Given this list of marker genes MAPK10, RPS6KA5, MAPK3, ELK1, MAPK8, ATF2, CREB1, PPP2R1B, MEF2A, RPS6KA3, MAPKAPK2, MEF2C, PPP2R5D, VRK3, RPS6KA2, JUN, PPP2CB (NCBI Gene Id 5516), FOS, DUSP3, RPS6KA1, ATF1, PPP2CA, DUSP7, MAPK7, MAPK11, DUSP4, PPP2R1A, DUSP6, MAPK9, MAPK1, MAPK14, here is a description of the gene set: MAPKs are protein kinases that, once activated, phosphorylate their specific cytosolic or nuclear substrates at serine and/or threonine residues. Such phosphorylation events can either positively or negatively regulate substrate, and thus entire signaling cascade activity. <p>The major cytosolic target of activated ERKs are RSKs (90 kDa Ribosomal protein S6 Kinase). Active RSKs translocates to the nucleus and phosphorylates such factors as c-Fos(on Ser362), SRF (Serum Response Factor) at Ser103, and CREB (Cyclic AMP Response Element-Binding protein) at Ser133. In the nucleus activated ERKs phosphorylate many other targets such as MSKs (Mitogen- and Stress-activated protein kinases), MNK (MAP interacting kinase) and Elk1 (on Serine383 and Serine389). ERK can directly phosphorylate CREB and also AP-1 components c-Jun and c-Fos. Another important target of ERK is NF-KappaB. Recent studies reveals that nuclear pore proteins are direct substrates for ERK (Kosako H et al, 2009). Other ERK nuclear targets include c-Myc, HSF1 (Heat-Shock Factor-1), STAT1/3 (Signal Transducer and Activator of Transcription-1/3), and many more transcription factors.</p><p>Activated p38 MAPK is able to phosphorylate a variety of substrates, including transcription factors STAT1, p53, ATF2 (Activating transcription factor 2), MEF2 (Myocyte enhancer factor-2), protein kinases MSK1, MNK, MAPKAPK2/3, death/survival molecules (Bcl2, caspases), and cell cycle control factors (cyclin D1).</p><p>JNK, once activated, phosphorylates a range of nuclear substrates, including transcription factors Jun, ATF, Elk1, p53, STAT1/3 and many other factors. JNK has also been shown to directly phosphorylate many nuclear hormone receptors. For example, peroxisome proliferator-activated receptor 1 (PPAR-1) and retinoic acid receptors RXR and RAR are substrates for JNK. Other JNK targets are heterogeneous nuclear ribonucleoprotein K (hnRNP-K) and the Pol I-specific transcription factor TIF-IA, which regulates ribosome synthesis. Other adaptor and scaffold proteins have also been characterized as nonnuclear substrates of JNK. part of: MAP kinase activation species: Homo sapiens Reactome Pathway: MAPK targets/ Nuclear events mediated by MAP kinases